Given this list of marker genes HRG, IL15, MIR199A1, MIR34B, MIR15B, MIR16-1, MIR27B (microRNA 27b), MIR214, PPP3CA, IL12B, ROCK2, MIR17, IL2 (interleukin 2), TMBIM1, MIR34C, IL21, ROCK1, IL18, IL23A, MIR195, MIR20A, MIR143, MIR34A, here is a description of the gene set: Human Gene Set: GOBP_POSITIVE_REGULATION_OF_TISSUE_REMODELING species: Homo sapiens Any process that activates or increases the frequency, rate, or extent of tissue remodeling.